Given this list of marker genes SIRT1, FOXO1, PTEN, MTOR, AKT1, IGF1R, here is a description of the gene set: species: Homo sapiens Human Gene Set: WP_SOMATROPH_AXIS_GH_AND_ITS_RELATIONSHIP_TO_DIETARY_RESTRICTION_AND_AGING Somatroph axis (GH) and its relationship to dietary restriction and aging